The following is a description of a gene set: Genes predicted to be targets of miRBase v22 microRNA mmu_miR_201_5p in miRDB v6.0 with MirTarget v4 prediction scores > 80 (high confidence targets). from publication Chen Y, Wang X (PMID 31504780) studied in species Mus musculus Mouse Gene Set: MIR_201_5P, and this is the list of marker genes: Nme7, Ino80d, Ncam1, Rora, Itga2, Klk1, Lyzl1, Arl8b, Calb1, Ppm1e, Mrgprb1, Pygb, Iapp, D3Ertd751e, Esyt2, Notch3, Gng10, Tstd2, Rev3l, Cblb, Iscu, Sestd1, 4930571K23Rik (NCBI Gene Id 75861), Sbno1, Nudcd1, Iqub, Tubgcp2, Scd2, Cdh3, Immt, Elovl4, B3galnt1, Zcchc4, Syncrip (NCBI Gene Id 78260), Psmd2, Spred1, Atmin, Flrt3, Fbxl20 (F-box and leucine-rich repeat protein 20), Lpl, Ankrd40, Ret, Tmem200c, Fance, Mcm3, Ptpn4, Il31, Itgad, Ptprd, Nsun6, Ubxn4, Lcorl, Scai, Sec24a, Haus8, Wnk1, Gpr18, Egr1, Snap23